The following is a description of a gene set: from publication Jeffrey KL, Brummer T, Rolph MS, Liu SM, Callejas NA, Grumont RJ, Gillieron C, Mackay F, Grey S, Camps M, Rommel C, Gerondakis SD, Mackay CR (PMID 16474395) Human Gene Set: GSE3982_MEMORY_CD4_TCELL_VS_TH2_UP studied in species Homo sapiens Genes up-regulated in comparison of memory CD4 T cells versus Th2 cells. In the present study we used Affymetrix oligonucleotide microarrays to produce gene transcription profiles for the major leukocyte types in humans. This comprehensive dataset enabled us to not only establish which genes were expressed in each leukocyte type, but also which genes were expressed in each subset after activation. The used of a comprehensive dataset of gene profiles from all the major human leukocyte subsets enabled a novel and powerful means for identification of genes associated with single leukocyte subsets, or different immune paradigms., and this is the list of marker genes: N4BP2L2, GIMAP5, ERBB2, OPTN, ADGRL1, NEUROG2, EZH1, GZMK, TRIM22, AGTR2, SLC46A3, ITGA5, HLA-DQB1, TPM1, SIK3, RPL30, TRAPPC11, RALGAPB, CARS2, MAML1, CASP1, CHFR, MX2, CALM1, TSC22D3, ANKEF1, CATSPERB, CHCHD7, ADARB1, PRR5L, IRF9, CD44, DDX5, MVB12B, ABCA7, CD96, TRIM5, JMJD1C, GUSBP11, TLE1, LSM14A, JADE2, SYNE2, CHKB, IL11RA, TRMO, ACKR3, CNGB3, ZKSCAN4, TFEB, PNLIPRP2, JAK1, RASGRF1, MYO6, AHCYL2, C14orf93, PRR15L, TMUB2, LY9, USP25, SLC18A3 (NCBI Gene Id 6572), EIF4A2, DGKI, MAP3K5, SGF29, SH2B1, CPQ, PLCG1, GOLGA8B, MACF1 (microtubule actin crosslinking factor 1), KLF6, BTN2A1, PGAP3, TTC12, KDM7A, ITK, KAT6B, DAZAP2, EIF1, USP3, CEP350, BTG1, EDNRA, NCOA6, HUWE1, N4BP2L1, SASH1, SNX29P2, AKT3, CRTAP, FKBP11, PLEKHG3, ASXL1, HERC1, MSL2, ARHGAP45, PRSS53, SCTR, CTSO, TGFBR2, ZNF37BP, CLSTN1, SUN2, KLHL20, ZFP36L2, CELSR1 (cadherin EGF LAG seven-pass G-type receptor 1), LTK, RETREG3, NAP1L2, MAGEA4, TNKS, RORA, POGLUT1, CDK11A, ZNF224, ANKH, RIPOR2, FAS, R3HDM2, GSAP, DIP2C, GSN, ZNF131, TBC1D8B, TRIM33, KIF5C, GLRA2, SGSM2, AQP3, PAFAH1B1, TMEM80 (NCBI Gene Id 283232), TMC6, DGKD, ST6GAL1, PIP4K2A, TASOR, RALGPS1, AKAP9, RASGRP1, BIN1, GDPD5, EPM2AIP1, POU5F1B, TCEAL9, BLTP1, ZDHHC17, AK1, KMT2D, HOXD10, PAH, NR3C2, CTSF, CD48, RIN1, BID, BCL11B, TPK1, ANXA1, LINC00623, GSDMD, SLC35C1, TNFRSF14, CAMTA1, GBP1, TSC22D1, INAVA, ADD3, SEC31B, PARP8, KCNK10, WDR59, TNXB, FOXJ3, CCR6, LPIN1, MCL1, MBNL1, PCDHB13 (protocadherin beta 13), DOP1A, PLSCR3, FOXO3, KIF16B, ABCA5, HLA-F, LTBP1, PBXIP1, RYR3, NECAP1, DCLK1, FBXW4, DGCR8, KLRB1, PARP6 (NCBI Gene Id 56966), OMG, CTDSP2, SESN1